Given this list of marker genes Arid5b, Myo1e, Zfp950, Csrnp1, Zfp640, 2610005L07Rik (NCBI Gene Id 436177), Txnip, Schip1, Zfand5, Sgpl1, Tiparp, Plekha1, here is a description of the gene set: Mouse Gene Set: SCHMAHL_PDGF_SIGNALING from publication Schmahl J, Raymond CS, Soriano P (PMID 17143286) species: Mus musculus Growth factor signaling leads to the induction or repression of immediate early genes, but how these genes act collectively as effectors of downstream processes remains unresolved. We have used gene trap-coupled microarray analysis to identify and mutate multiple platelet-derived growth factor (PDGF) intermediate early genes in mice. Mutations in these genes lead to a high frequency of phenotypes that affect the same cell types and processes as those controlled by the PDGF pathway. We conclude that these genes form a network that controls specific processes downstream of PDGF signaling. These genes form a a network that controls specific processes downstream of PDGF signaling.